Given this list of marker genes MMP13, MYD88 (MYD88 innate immune signal transduction adaptor), AKT1, INS, CASP8, IRS1, MAPK14, RAC1, MAPK1, MAPK3, AGER, LGALS3, STAT1, SOD1, RAF1, ALPL, STAT3, CHUK (NCBI Gene Id 1147), NOS3, CASP3, PRKCA, CDC42, HIF1A, RELA, MAP2K1, PRKCZ, MMP2, STAT5A, MSN, SMAD3, MAPK8, PRKCB (protein kinase C beta), INSR, FOXO4, EGFR, IRAK4, STAT5B, NFKBIA (NFKB inhibitor alpha), ROCK1, MSR1, MMP9, CASP9 (NCBI Gene Id 842), IKBKB, NCF1, JUN, MMP14, MAPK9, RHOA, PLA2G4A, NFKB1, INHBB, PRKCD, CYCS, SMAD2, SP1 (Sp1 transcription factor), ATF2, TIRAP, SHC1, EZR, FOXO1, NOS2, DIAPH1, JAK2, MMP7, DDOST, SRC, here is a description of the gene set: studied in species Homo sapiens Human Gene Set: WP_AGERAGE_PATHWAY AGE/RAGE pathway